The following is a description of a gene set: Heterochromia iridis is a difference in the color of the iris in the two eyes. species: Homo sapiens Human Gene Set: HP_HETEROCHROMIA_IRIDIS Heterochromia iridis, and this is the list of marker genes: SALL4 (NCBI Gene Id 57167), ELP1, EDC3, PNPLA6 (patatin like phospholipase domain containing 6), KITLG, SNAI2, MITF, MC1R, OCA2, TYR, KIT, MAFB, EDN3, ACTB, EDNRB, PAX3, ACTG1, PTEN, GNAQ, CHN1, LMX1B, HRAS, AKT1 (NCBI Gene Id 207), SOX10